Given this list of marker genes SALL4, MAFB (NCBI Gene Id 9935, MAF bZIP transcription factor B), BMPER, GDF3, MEOX1, FUZ, FGD1, GDF6, VANGL1, CHN1, FLNA, here is a description of the gene set: species: Homo sapiens Human Gene Set: HP_ABNORMAL_VERTEBRAL_SEGMENTATION_AND_FUSION Abnormal vertebral segmentation and fusion